The following is a description of a gene set: Mouse Gene Set: ZFP738_TARGET_GENES studied in species Mus musculus from publication Yevshin I, Sharipov R, Kolmykov S, Kondrakhin Y, Kolpakov F (PMID 30445619), and this is the list of marker genes: Jtb, Sh3kbp1, Mis18bp1, Kbtbd12, Ranbp3 (NCBI Gene Id 71810), Cfap45, Atp5pb, Gramd1b, Apex2, Mbd4, Sos1, Casc3, Gm2287, Spring1, Sergef, Resf1, Ift122, Crot, Nckap1, Cox7a2, Tsen34, Clec12b, Mboat7, Ogfrl1 (opioid growth factor receptor-like 1), Gm16096, Ids, Ehbp1, Nmnat2, Tbc1d32, Hapstr1, Armcx1, Xkr5, Ciao2b, Mbd5, Synj1, Gm24432, Ppp2r2b, Zfp950, Fos, Bphl, Cenpc1, Orc4, C9orf72, Tssc4, Pde4d, Mrps31, Pxn, Gm14133 (NCBI Gene Id 100503289), Clec2d, 1700082M22Rik, Cept1, Rnft2, Wdr77, Gm12571, Myadml2, Dhodh, Zfp428